Given this list of marker genes Stx7, Stx1a, Stx8, Ano9, Vti1b, Cftr, Vamp8, here is a description of the gene set: Mouse Gene Set: GOMF_CHLORIDE_CHANNEL_INHIBITOR_ACTIVITY Binds to and stops, prevents, or reduces the activity of a chloride channel. studied in species Mus musculus